The following is a description of a gene set: Mouse Gene Set: GOBP_FOLIC_ACID_METABOLIC_PROCESS studied in species Mus musculus The chemical reactions and pathways involving folic acid, pteroylglutamic acid. Folic acid is widely distributed as a member of the vitamin B complex and is essential for the synthesis of purine and pyrimidines., and this is the list of marker genes: Dhfr, Aldh1l1, Mtrr, Aldh1l2, Mthfsl, Shmt1, Pm20d2, Folr1